Given this list of marker genes NLRP3, IL1B, PYCARD, CASP1, RELA, TRAF3, NFKB1, here is a description of the gene set: studied in species Homo sapiens Human Gene Set: WP_ACTIVATION_OF_NLRP3_INFLAMMASOME_BY_SARSCOV2 Activation of NLRP3 inflammasome by SARS-CoV-2